Given this list of marker genes PRKACA, NMU, DNM1L, CARTPT, GABBR1 (NCBI Gene Id 2550), GPLD1, STXBP1, MPC2, GAL, GIPR, NPR1, HLA-F, FGB, OXCT1, PDCD6IP, RAB5A, CACNA1B, DYNLL1, OXT, TM7SF3, SLC18A3, SYT10, CAPN10, GOLPH3L, CDK5, ABCC8, FRMD4A, BGLAP, INHBB, RFX6, PTPN11, TGFB2, UNC13B, TSG101, KCNB1, RAB3A, GPR158, GOLPH3, F2RL1, STX1B, FGG, NTSR1, PTPN23, IER3IP1, ANKRD1, CYP4A11, MYH10, SCAMP5, NR0B2, ADORA2A, TLR4, PRKN, ADCYAP1 (adenylate cyclase activating polypeptide 1), GCK, GPR68, CLASP1, CADPS, BAIAP3, RGCC, SLC4A8, TNFSF11, CYP19A1, STAM, P2RY1, TACR2, RPH3A, NEGR1, SYT1, GHRH, GLUD1, TLR2, FCER1G (NCBI Gene Id 2207), TRPM4, STX1A, CXCL12, PRKCE (protein kinase C epsilon), INS, SCT, VEGFC, GDNF, NPPB (natriuretic peptide B), FGA, BSG, CHRM3, ILDR1, PFKFB2, PCK2, SCIN, INHBA, MYO18A, CYBA, PHPT1 (NCBI Gene Id 29085), ACSL4, SYT4, ADAM9, AQP1, PARD6A, SPHK2, ADAM8, RHBDD1, CDK5R2, TMEM132A (NCBI Gene Id 54972), GRK2, SIRT3, HGS, TMED10, PLA2G3, TRPM5, SPP1, RUFY4, APLN, GHRL, GAB2, LEP, GHRHR, IL13 (interleukin 13), SYTL4, DAB2, RAB27A, NLGN2, STXBP5, HLA-DRB1, VPS4B, PLA2G1B, C1QTNF12, ARF6, SOX11, CD177, DOC2A, GIP, APBB1, NKX3-1, DOC2B, NMB, INHA, IL1B, KMO, ITSN1, IL1A, SNF8, P2RX7, CHMP2A, MLXIPL, RAB27B, ADCY8, ACHE, CASR, TAC1, PLA2G6, DRD2, ECRG4, CHRNB2, GPR27, PSMD9, HYAL3, HIF1A, FFAR2, ATP13A2, LRRC8A, C1QTNF1, ITPR1, VPS4A, KCNN4, SNCA, PLA2G4A, ABAT, SLC6A4, SELENOT, ORAI1, IRS2, TACR1, S100A10, SLC30A8, NPY2R, ALOX12B, FOXL2, OPRK1, TGFB1, SMAD4, LACRT, HCAR2, CLASP2, PDX1, FGR, F2RL2, OSBP, TNFRSF11A, PPID, IL4R, PRKCA, MIF, PPP3CB, PLCB1, P2RY2, FUT10, NKX6-1, ADORA1, DTNBP1, TFR2, FFAR4, SLC12A2, STX4, OR51E2, GPER1, NNAT (neuronatin), TTN, SEC24A, RAB3D, SLC2A2, ITGB2, RETN, RAB3GAP1, XBP1, UCN, SYBU, SDC1, PPARG, TREM2, NLGN1, PRKAR1A, ZP3, PINK1, GATA1, TGFB3, CD2AP, RAB9A, AP1G1, BMP6, ACSL3, MIR199B, ABCG1, EDN3, RPH3AL, SMPD3, TMF1, GRP, RAB2B, ANG, C1QTNF3, PPIA, CYP4F2, ABCB11, TRH, FFAR1, SOX4, NR1H4, NADK, FUT11, UNC13D, PRKCB, IFNG, EXPH5, RBP4, SDC4, CD33, CRH, PRL, C2CD2L, PLA2R1, TARDBP (NCBI Gene Id 81927), MYB, BLK, RASL10B, RAB7A, VAMP8, AIMP1, F2, MICU3, SYK, VSNL1, ANXA2, PLA2G10, ATG5, SIRT6, MYRIP, GALR1, S100A8, TCF7L2, EDN1, FGFR1, ADORA2B, JAK2, PPARD, PPP3CA, AVPR1A, PTGES, ITGAM, GCG, APBB3, SERP1, BMP2, AACS, GPRC6A, AVP, CD38, UCN3, SYT7, TRPA1, RAC1, NR1H2, AVPR1B, WLS, RAPGEF4, MCU, BAD (BCL2 associated agonist of cell death), P2RX4, PRKD1, KLRC2, PFKM, MYOM1, RAB8B, ANO1, HFE, SNX4, CFTR, VAMP7, CREB1, GATA2, ISL1, VPS35 (VPS35 retromer complex component), RAB15, GNA11, SDCBP, CD160, TUNAR, IGF1, CADPS2, LAMP1, here is a description of the gene set: species: Homo sapiens Human Gene Set: GOBP_POSITIVE_REGULATION_OF_SECRETION Any process that activates or increases the frequency, rate or extent of the controlled release of a substance from a cell or a tissue.